The following is a description of a gene set: Mouse Gene Set: GOBP_POSTSYNAPTIC_MEMBRANE_ORGANIZATION A process which results in the assembly, arrangement of constituent parts, or disassembly of a postsynaptic membrane, the specialized area of membrane facing the presynaptic membrane on the tip of the nerve ending and separated from it by a minute cleft (the synaptic cleft). species: Mus musculus, and this is the list of marker genes: Rer1, Dnaja3, Sorbs2, Agrn, Ptn, Reln, Glrb, Shank3, Fzd9, Shisa6, Shisa7, Colq, Lrrc4, Cit, Dbn1, Cdh2, Nlgn1, Crk, Rapsn, Nlgn3, Gdnf, Lrp5, Chrnb1, Apoe, Nrxn2, Grip2, Cript, Htr1a, Frrs1l, Dlg4, Gphn, Crkl, Slc30a1, Zmynd8, Zdhhc2, Dok7, Musk, Snx27, Mesd, Sorbs1, Dvl1, Magi2, Fnta, Nrxn1, Lrp4, Farp1, Slc7a11, Rac1, Lrrtm4, Lhfpl4, Ssh1, Chrdl1, Nlgn2, Ephb2, Etv5